Given this list of marker genes BMP4, PTCD3, HSD17B11, ACAP2, NKTR, TBPL1, C7orf25, PTK6, ZMYND8, KHDC4, CENPA, CENPI, RANGAP1, REPIN1, RSBN1, KLHDC10, STIP1, ELOVL1, GADD45B, PRR16, PEX10, STK17B, CDKN1B, BICRAL, TRMU, PLA2G12A (NCBI Gene Id 81579), RFC2, SLC33A1, GTSE1, FGD6 (FYVE, RhoGEF and PH domain containing 6), XYLT1, PIKFYVE, RPS4XP3, RAD51AP1, DRAP1, NEK2, CAPN7, MAGOH, TGIF1, KIF22, CDK1, MAP4K5, TFAP2C, REV3L, NET1, NEAT1, NDC80, BAG2, MARS1, UBBP2, MSH5, CRYGS, CDK5R1, PSRC1, PERP, CCDC85B, HES1, TMEM160, RPS9, BUB3, RSAD1, DPYSL2, LGR4, SDF4, BHLHE41, ZMYM1, PER3, CKS2, ITGB1, NDUFA5, SIRT1, TUFT1, SFTPC, MDM1, VAMP4, TST, DLEU1, RAP2B, SKP2, ESM1, ITGA4, CEP55, GAS2L1, FBXL18, GTF2I, PDE4DIP, VPS13C, EIF4EBP1, BUB1, CITED2, APOE, IGF2BP3, LSM5, SLC5A3, ORC5, ZBTB20, RAD50, MAPK14, AKAP1, TRAM2, YEATS2, SHH, SMC3, CD24P2 (NCBI Gene Id 936), CEP350, PDF, SPTSSA, NUDT6, HSPA1A, AASDHPPT, HBP1, DERA, ASCC3, CKLF, GADD45GIP1, CUL4A, MAP4K3, MRPL34, RWDD3, IQSEC2, C2CD5, CHMP5, CDC20, ZZZ3, PPWD1, PMS1, ZNF302, LIAS (lipoic acid synthetase), TNFAIP8, IFI16, APAF1, PAPOLA, ATF2, CCND1, BDNF, CCNG2, NOX1, KIF20A, TGFB2, GLRB, IFT74, FAM111A, ATP10D, ARMCX6, SMURF2, SHCBP1, FARSA, GMNN, MIS18BP1, FAM106A, OIP5, TRIM27 (NCBI Gene Id 5987), DLC1, TIA1, MYBL1, PPM1A, NAA40, FNBP4, NCAPG, HSPA13, MZT2B, PIK3R3, MAD2L1, SHMT2, GLT8D1 (NCBI Gene Id 91870), FLRT2, TRIM25, EDF1, SNRPA1, CKAP2, MRPL19, GJA1, GPALPP1, TMPO, ITGBL1, EFHC1, OARD1, PCNX4, ZCCHC2, ABCD3, LARP4, CTR9, PRPF31, APPBP2, TCF7L2, DGCR2, NUAK1, PPM1B, AURKB, ZNF34, MRPS18B, EID1, SPN, NDC1, ARMCX2, ASNS, WSB1, CDCA8, HADH, RPS25, TCAF1 (TRPM8 channel associated factor 1), HJURP, BARD1, AURKA, RBM25, PRMT7, TTK, SEMA3C, IRF2, RAB29 (NCBI Gene Id 8934), BAZ2B, CENPC, TOB1, HOXB13, GTF2H5, MRPL13, UBE2G1, SUGP2, KIF18A, PPM1D, MNS1, RANBP6, RAD51C, HOXB6, PIGF, UPF3A, ARL6IP1, PLK2, TMEM165, FUBP1, ASF1A, MYG1, TECR, RAD21, ST6GALNAC5, NBR1, RACGAP1, RSRP1, ESPL1 (NCBI Gene Id 9700), DLGAP5, LIN37, MANF, POLR2D, KLHL2, BAD, SRSF10, RCOR3, LSM4, LMO4, ARL4A, KANSL2, HSPA5, PI4KB, ACKR3, BRD8, DNAJB1, ZFP64, RIN2, DENND4C, SDF2L1, SAC3D1, CDC7, METTL3, SNAPC1, NFATC3, ARMCX1, PSMC3, SEC24D, SCRT1 (scratch family transcriptional repressor 1), TAF5, SOD2, WDR13, SLC26A2, POLD4, ACYP1, KCNJ12, FZD2, ID1, FCF1, POP5, CDK10, PIMREG, GPSM2, HEMK1, GOLPH3L (golgi phosphoprotein 3 like), PRPF40A, MEPCE (methylphosphate capping enzyme), HSPA1B, BUB1B, LIPT1, KIF23, DPF2, PLA2G4A (NCBI Gene Id 5321), AGAP1 (NCBI Gene Id 22851), ESS2, MBNL2 (NCBI Gene Id 55479), MGAT2, CREM, TUBGCP3 (tubulin gamma complex component 3), TMEM267, MPHOSPH9, AIRIM, PARP2, ANKRD12, GSTK1 (NCBI Gene Id 51064), COPS5, PCGF1, ACTR2, LAMTOR5, USP33, H2BC12L, CTCF, NELFA, FAM200C, GNAI1, PLOD2, TBC1D31, CEP76, ELOVL6, HNRNPC, F2RL1, PRIM2, KDM3A, IFIT1, RHOBTB1, GOLGA8G, GRK5, C17orf75, ASPM, TPRA1, MED21, LAGE3, EIF2AK3, TMEM120B, E2F5, MIR3648-1, ACOXL, IRS1, IMP3, ARL4C, CENPE, NRP1, MOCS1, BCL2L1, PPP2R5C, H2BC6, CRKL, HOXA9, TRIM5, DBF4, KIF2C, SLC38A6, RAB6A, NUSAP1, NMT2, KIF14, FASTKD1, RABGGTB, CPOX, CENPF, RDH11, KRT10, PPIG, DAAM1, LAMB1, CDCA3, SLC38A2, ID2, MGAM, H2AZ2, CYP24A1, LUM, PGGHG, WIPI1, DDIT4, SERP1, NRG1, SLF2 (NCBI Gene Id 55719), STAM, TOP2A, OXA1L, SNTB2, MAGT1 (NCBI Gene Id 84061), CETN3, BMPR1A, DNPH1, ADSS2, COL1A1, CCNF, GRSF1, DNAJB4, TBRG4 (transforming growth factor beta regulator 4), TM2D3, FAAP24, CDK2AP2, PRDX2, TBC1D9, FAM149B1, SGK3 (serum/glucocorticoid regulated kinase family member 3), PMAIP1, PLAGL1, HIKESHI, BMP5, NR2F2, SRSF11, BRWD1, TTF2, SLC25A46, SERF2 (NCBI Gene Id 88287), THOC7, GLS, PILRB, PARG, THAP11, MTAP, DNAAF2, ZNF292, SDHAF3, DNAJB6, REV1, NBN, ASAH1, CDC42EP3, RAPGEF2, HYAL4, SEC22B, CDC14A, MARCO, ZBTB18, GEMIN2, CPT1B, ARMC1, TRMT1L, SGMS1, PHF3, ACTR6 (actin related protein 6), RPL36, ZBED5, ZNF205, CDC40, NFYB, DERL2, CEP57, ATP6AP2, NDUFA4, HMGB2, BECN1, ZCCHC8, TOB2, FXR1, LSM2, ZNHIT1, RMDN1, NIF3L1, TPTE, CDK8, INTS13, NCOA2, CCNA2, FUBP3, PKP4, ATP5MC2P1, SOAT1, HAPLN1, HTATIP2, PSPH, ZNF184, APEH, KIF11, PITX2 (NCBI Gene Id 5308), HMGN5, TIAL1, here is a description of the gene set: studied in species Homo sapiens The Wilms' tumor suppressor gene (WT1) encodes a zinc finger transcription factor that is vital during development of several organs including metanephric kidneys. Despite the critical regulatory role of WT1, the pathways and mechanisms by which WT1 orchestrates development remain elusive. To identify WT1 target genes, we performed a genome-wide expression profiling analysis in cells expressing inducible WT1. We identified a number of direct WT1 target genes, including the epidermal growth factor (EGF)-family ligands epiregulin and HB-EGF, the chemokine CX3CL1, and the transcription factors SLUG and JUNB. The target genes were validated using quantitative reverse transcriptase-polymerase chain reaction, small interfering RNA knockdowns, chromatin immunoprecipitation, and luciferase reporter analyses. Immunohistochemistry of fetal kidneys confirmed that a number of the WT1 target genes had overlapping expression patterns with the highly restricted spatiotemporal expression of WT1. Finally, using an in vitro embryonic kidney culture assay, we found that the addition of recombinant epiregulin, amphiregulin, CX3CL1, and interleukin-11 significantly enhanced ureteric bud branching morphogenesis. Our genome-wide screen implicates WT1 in the transcriptional regulation of the EGF-family of growth factors as well as the CX3CL1 chemokine during nephrogenesis. Genes down-regulated in UB27 cells (osteosarcoma) at any time point after inducing the expression of a mutant form of WT1. Human Gene Set: KIM_WT1_TARGETS_DN from publication Kim HS, Kim MS, Hancock AL, Harper JC, Park JY, Poy G, Perantoni AO, Cam M, Malik K, Lee SB (PMID 17430890)